The following is a description of a gene set: species: Homo sapiens Human Gene Set: GOBP_LEUKOCYTE_APOPTOTIC_PROCESS Any apoptotic process in a leukocyte, an achromatic cell of the myeloid or lymphoid lineages capable of ameboid movement, found in blood or other tissue., and this is the list of marker genes: SELENOS, GPAM, ANXA1, FNIP1, LGALS16, NR4A3, BCL2L11, PIK3CB, P2RX7, PDCD1, MIR17HG, CRKL, MIF, CHEK2, MEF2C, CD27, WNT5A, FASLG, CXCL12, SIRT1, RIPK1, PRKCQ, CASP9, IL10, ADA, FCER1G, ARG2, RIPK3, CD74 (CD74 molecule), PRELID1, PIK3CD, CD274, SIVA1, RAPGEF2, IDO1, AURKB, TRAF3IP2, MIRLET7B, DOCK8, BMP4, NFKBIZ, HCAR2, ITPKB (NCBI Gene Id 3707), NOC2L, CLC, CCL5, BBC3, KDELR1, IRS2, BCL2L1, TNFRSF21, EFNA1, HCLS1 (hematopoietic cell-specific Lyn substrate 1), RAG1 (NCBI Gene Id 5896), ORMDL3, STAT5A, MYC, SLC7A11, CDKN2A, LILRB1, ZC3H8, NF1, DFFA, BAX, LYN, MIR34A, CTSL, PERP, TGFB2, CCL21, IL2RA, CCL19, CCR7, IRF7, KIFAP3, MERTK, BIRC7, LIPA, PRKD2, BCL2, DNAJA3, CASP7, PTCRA, FCAR, ST3GAL1, PKN1, TP53 (tumor protein p53), AXL, BCL10, JAK3, LMBR1L, CD3G, KITLG, IL6, CCR5, IL2 (interleukin 2), FAS, RORC, BCL6, ADAM17, GIMAP8, SLC39A10, LGALS9 (NCBI Gene Id 90793), PLEKHO2, CASP3, TSC22D3, BTK, LGALS3, IRF3, GAS6, GLI3, FOXP1, BCL11B, HIF1A, NOD2, IL7R, ADAM8, PIP, EBF4, SLC46A2, GHSR, AKT1, FADD, BAK1, HSH2D, BCL3